Given this list of marker genes Crym, Bmper (NCBI Gene Id 73230), Epyc, 2810442N19Rik, Or4c114, Gm4425, Gm20756, Pax9, Esr2 (estrogen receptor 2 (beta)), Col9a2, 9330136K24Rik, 1500002C15Rik, 1700018A04Rik, Has1, Wwp2, Col2a1, Gm10578, 9130410C08Rik, 1700019A02Rik, Gm28154, Gm12830, Col9a3, Col9a1 (NCBI Gene Id 12839), here is a description of the gene set: Mouse Organogenesis Cell Atlas (MOCA) DE_gene_main_cluster.csv, fold.change>=1.5, qval<0.05, pval<0.05 studied in species Mus musculus from publication Cao J, Spielmann M, Qiu X, Huang X, Ibrahim DM, Hill AJ, Zhang F, Mundlos S, Christiansen L, Steemers FJ, Trapnell C, Shendure J (PMID 30787437) Mouse Gene Set: DESCARTES_ORGANOGENESIS_JAW_AND_TOOTH_PROGENITORS